The following is a description of a gene set: The hydrolysis of a peptide bond or bonds within a protein as part of the chemical reactions and pathways resulting in the breakdown of a protein by individual cells. Human Gene Set: GOBP_PROTEOLYSIS_INVOLVED_IN_PROTEIN_CATABOLIC_PROCESS species: Homo sapiens, and this is the list of marker genes: CAMLG, TRIM31, UBAP1, HSP90AB1, UBQLNL, ANKRD9, TRIM2, DVL1, TBL1XR1, TAF9 (TATA-box binding protein associated factor 9), DAB2, UBE3D, KLHL2, HSPA1A (heat shock protein family A (Hsp70) member 1A), PSMD3, GBA1, CTSH, SOCS4, PTPN23, FBXL18 (NCBI Gene Id 80028), TRIM9, VPS25, RPS27A, TMTC3, CEBPA, AURKA, FAF2, TMEM129, DNAJB2, CUL3, LONP2, MAGEF1, KLHL10, WNT10B, KLHL22, FBXW8, OPHN1, GIPC1, DNAAF4, ADRM1, NHLRC3, IL33, SKP1, PRAMEF17, IFI27, TMEM168 (transmembrane protein 168), SVIP, RHBDF1, RNF125, ARMC5, NEDD4L, EIF3H, CUL4B, RNF20, GLMN (glomulin, FKBP associated protein), RNF213, PRAMEF14, CTSF, SHH, WAC, WWP2, DCAF11, LAPTM5, APOE, USP38, ANAPC16, PSMB11, RNF150, HECW1, CTNNB1, FBXO46, PRAMEF11, UBE2L3, PTK2, SPOP, PSMC2, BIRC2, TF (NCBI Gene Id 7018), EPM2A, PSMB10, LONP1, PCNP, FBXO45, CDC23, RNF11, UHRF1, MIB1, RNF133, FBXL12, AKT1, ZRANB1, PSME3IP1, SOCS5, PMAIP1, KLHL18, PRKCG, RBBP6, PSMB8, HERPUD1, CAPN2, ANAPC5, ANKZF1, MAN1C1, PRAMEF12, VPS36 (vacuolar protein sorting 36 homolog), ZNRF4 (NCBI Gene Id 148066), KBTBD12, FAU, RCHY1, TMEM259, PRKACA, MVB12B, RPL11, TTC36, RNF123, RNF13, PDCD6IP, UBQLN3, ATXN3L, DMAC2, DET1 (DET1 partner of COP1 E3 ubiquitin ligase), PDCL3, GSK3A, DERL1, KLHL3, RNF185, FBXL3, RNF128, RNF40, ERLEC1, PTEN, PSMA2, GZMB (granzyme B), PSMA3, TRAF7, DAB2IP, ANAPC10, RNF139, BAG2, PHF20L1, TRIM13, VPS28, SUMO2, CHMP4A, MAP1A, PEX12, CTSK, UBL4A, CUL7, RNF187, CALR3, SNF8, UBL7, TRIP4, RHBDD2, PPP2CB, USP17L6P, ANAPC11, IVNS1ABP, VPS37C, FBXO22, PSMD14, NEURL3, ERCC8, ARRDC1, NEMF, UBXN8, SMARCC1 (NCBI Gene Id 6599), JKAMP, SUFU (NCBI Gene Id 51684), SAYSD1, ASB2, DTX4, XPO1 (exportin 1), ZFAND2A, GCLC, UBE2H, RPL23, CBLC, MAEA, UBA52, TRIB2, KLHL20, PELI1, ASB1, PSME1, HAMP, UBA1, GZMA, PSME3, KLHDC2, GID4, ANAPC15, NKD2, CACUL1, AXIN1, BRINP1, RSPRY1 (ring finger and SPRY domain containing 1), PRAMEF5, PSMB3, DCAF1, APPBP2, PARK7, CHMP4BP1, KLHL7, UBE3A, RHBDD1, FBXO31, RNF41, PSMD9, MIDN, RNF25, IKBKG, USP17L24, RAD23B, RNF19B, TRIM58 (tripartite motif containing 58), STAM (signal transducing adaptor molecule), UBE2B, WDR91, VPS4A, CDK2, PSMB4, PLK1, CSNK1A1, RNF26, CPA1, UBE2S, UBE2C, LAMP3, PSMA7, TOR1A, SKP2, CLOCK, KLHDC10, HSP90B1, UBE4A, KCTD17, HERC5, XBP1 (NCBI Gene Id 7494), ECRG4, DNAJC3, PRAMEF25, PSMB5, ZER1, AGAP3, UBE2L5, ALAD, UBE4B, UBE2J2, MTOR, BAP1, HECW2, FBXW7, EGF, FBXO11, RMND5A, FBXL14, KCTD5, RNF8, ZNF598 (zinc finger protein 598, E3 ubiquitin ligase), PSME2, NEDD8, CLPX, ZNRF1, TNFAIP1, KLHL30, DDI2, PABIR1, SOCS6, UBE2N, MALT1 (MALT1 paracaspase), TNFAIP3, WFS1, GSK3B, KLHL41, MIR128-1, CCAR2, PSMF1, CTSL, CHMP2B, AMBRA1, ATP5IF1, FBXO3, PPP2R5C, CHMP3 (charged multivesicular body protein 3), FBXL19, UFSP2, PRAMEF19, ENC1, VHL, AMN1, UBR4 (NCBI Gene Id 57525), HERC6, AXIN2, PSMD10, TRIM26, CANX (calnexin), RHOBTB3 (NCBI Gene Id 22836), KLHL23, NPLOC4, PITHD1, KLHL28, IRGQ, OS9, ATF6, TAF1, LIAT1, RNF148 (NCBI Gene Id 378925), SEM1, CCAR1, PRKN, FBXO4, RNF34 (ring finger protein 34), GET4, NR1D1, CHMP1A, CDC27, RNF130, RNF103 (ring finger protein 103), NDFIP1, CTSB, LATS1 (large tumor suppressor kinase 1), UCHL1, TRIB1, CTSC, PINK1, TRAF4, UBE2W, RNF19A, L3MBTL3, PRAMEF7, UBXN2A (NCBI Gene Id 165324), CDC34, RNF43, DDRGK1, FBXL2, RNF170, SIRT1, KLHL17, KLHL8, CALR, RNF114, EDEM3, STT3B, TMF1, SPSB3, FAM8A1, FBXL5, HERC4, LRRK2, CCDC47, OMA1, NDFIP2, CASP8, RPGR, FBXL15, CBFA2T3, RNF180, AKIRIN2, PSMC4, PABPN1L, SGTA, UBE2Z, DNAJB9, TTC3 (NCBI Gene Id 7267), RNF4, SELENOS, CSNK2A2, PSMC5, KCTD10, DERL2, SOCS2, APC, UBE2I, RACK1, MAN1A2, MTM1 (myotubularin 1), CSNK2A1, SIRT6, SMURF2, COPS3, SUMO1, PEX10, AFG3L2, WWTR1, KLHL1, PSMC1, ANAPC1, DNAJB12, TMX1, UCHL5, PRAMEF15, PJA2, RNF10, UBXN4, PPP1R11, KLHL15, RNF121, MAN1B1, LONRF2, EFNA1, UBE2J1, TRIM32, FOXRED2, KLHL42, HUWE1, PRAMEF10, RNF215, USP14, TBL1X, UBE2D1, KLHL24, CDKN2A, CLU, ZYG11B, SH3RF1, AQP11, IPP, ZNRF3, PSMD8, KBTBD2, SIAH3, OGT, KLHL6, UBXN1, RNF126, MTA1, UBA6, BBS7, SHARPIN, F8A2, GABARAPL2, CDC20B, FBXL17, FEM1B, RNF217, TBX21, UBE3C, ECPAS, RPS7, FBXO44, FBXL7, RNF167, UBAP1L, EDEM2 (ER degradation enhancing alpha-mannosidase like protein 2), PSMD4 (proteasome 26S subunit ubiquitin receptor, non-ATPase 4), LRRC75A, ARAF, UBXN2B, RAD23A, RNF6, UBXN6, CHMP7, NFE2L2, SEC61B, AGBL4, UBE3B, CLPP, AUP1, DTL, IFT80, MYLIP, AREL1, TRPC4AP, UBR7, CUL9, HDAC6, UBQLN1, DCST1, CSNK2B, UBE2K, NHLRC1, PANO1, FBXO38, KEAP1, UBE2D4, TRIM72, WDR26, RNF145, KLHDC3, USP26, VPS37D, KLHL35 (NCBI Gene Id 283212), CSNK1E, RNF166, PLK3, FBXL6, GAN, UBC, PRAMEF27 (PRAME family member 27), PSMD2, WDR77, ITCH, KAT5, UBE2A, UBAC2, UBE2E1 (NCBI Gene Id 94682), PRAMEF4, UBQLN2, CCDC22, TOM1L1, CHMP4C, RPL5, TREM2, RNF168, PSMA1 (proteasome 20S subunit alpha 1), RNF144B, STYX, KLF1, SIAH1 (siah E3 ubiquitin protein ligase 1), EPG5, FAP, KCNE2, USP33 (ubiquitin specific peptidase 33), OTUD7B, LNX1, TRIM71, CHMP4B, ASB11, WDR81, CHMP2A, COMMD1, SYVN1, SMURF1, FBXW5, UBR2, RNF144A, KLHL40, DDI1, RNF186, GABARAP, HECTD1, SIRT2, TMUB1, BMAL1, OTUD7A, UBQLN4, EDEM1, TP53INP2, PSEN1, FEM1A, RLIM, FBXO48, NSFL1C, UCHL3, CTSZ, RNF111, PCBP2, FBXO10, ANAPC2, CHFR, AGTPBP1, UFL1 (UFM1 specific ligase 1), KCTD6, ERLIN2, CLGN, NUDT15, ARHGAP5-AS1, ZFAND2B, RNF149, ZNF418, PSMC3 (NCBI Gene Id 96121), KLHL11, NUB1, DTX3L, HACE1, KLHDC1, RNF5, LGMN, PSMB7, CHMP1B, PCYOX1, FBXO17, SEL1L2, TMEM67, CRBN, FBXW11, CUL1, EPHA4, DDB1, FAF1, UBE2G2, ADAMTS7, HFE, KLHL21, RNF122, SPSB1, ANAPC7, RC3H2, ISG15, FBXO6, ECSCR, CSNK1D, SMAD7, KCTD2, SPSB4, USP19, USP28, HERC2, BAG6, RNF216, RNFT1, MDM2 (MDM2 proto-oncogene), GPX1, SH3RF3, PRAMEF13, PML, RNF7, UBR1, UBE2L6, FBXW4, NOP53, TRIM39, TRIM3, F8A1, UBR5, PTK2B, ADAMTS12, RYBP, PSMD12, RC3H1, RNF14, PSMD13, RNF175 (NCBI Gene Id 285533), F8A3, KBTBD8, CDK5RAP3 (NCBI Gene Id 92989), ARK2N (NCBI Gene Id 147339), RNF115, NTAN1, USP5, YOD1, AFG2B, ERLIN1, PSMB6, NEDD4, ARIH1, UBE2D3, FBXO9, FBXL13, TRIP12, COP1, RMND5B, TRIM25, LTN1, ARRB1, PRAMEF20, SDF2L1, PBK, NCCRP1, SH3RF2, WWP1, VPS37B, HERC3, ZNRF2, RFFL, ANKIB1, KBTBD6, PAQR3, TRIM28, SH3BGRL, IDE (insulin degrading enzyme), QRICH2, TGFB1I1, PRICKLE1, KLHL38, ARIH2, PSMA5, FMR1, FBXO8, MAN1A1, UMOD, FBXL16, SOCS7, KLHL12, CTSV, PRAMEF26, WNT1, PRAMEF6, MVB12A, PRAMEF2, PIAS1, AMFR, UBE2R2 (ubiquitin conjugating enzyme E2 R2), DCAF13, PKD1, NUPR1, OXA1L, RNF146, STUB1 (STIP1 homology and U-box containing protein 1), USP7, SEL1L, MARCHF7, PRAMEF1, RBCK1, TRIM67, TMEM126A, PRAMEF22 (NCBI Gene Id 653606), PSMC6, ASCC2, CDC16, CTSW, PRAMEF18, SPOPL, CCNF (NCBI Gene Id 899), MARCHF6, ANAPC4 (NCBI Gene Id 29945), UBE2G1, STAM2 (NCBI Gene Id 51453), RCN3, SQSTM1, FBXO2 (NCBI Gene Id 4930), DDIT3, DDA1, KCTD13, OSBPL7, BCAP31, PYHIN1, KLHL4, APC2, FBXO7, KCMF1, SENP1, KLHL25, UBB, NFE2L1, FBXL22, FBXO39, UBA7, PCYOX1L, KBTBD7, UBXN11, PSMD1, CHMP5, CNOT4, HGS, BTRC, PSMA4, FBXL20, TMUB2, PRMT6, HM13, KBTBD3, PSMD11, ELOC (NCBI Gene Id 6921), SPSB2 (NCBI Gene Id 84727), KLHL29, PRPF19, PRAMEF9, PSMA8, TRIM38, N4BP1, RBX1, FBXL4, UBE2D2, PSMD7, RNFT2 (NCBI Gene Id 84900), PRAME, USP44, DISC1, GNA12, GID8, HSPA1B, UBXN10, KCTD21, DCAF12, BFAR, VPS4B, KLHL5, NAGLU, ZSWIM8, ELOB (elongin B), YME1L1, PRAMEF33, TOLLIP, USP13, FEM1C, CTSS, MAPK9, DESI1, TRIM21, CDC20, KIF14, DNAJC10, ASB9, CCIN, TRIB3, TSG101, PLAA, FBXO27, CUL4A, CAV1, FBXO21, UBE2U, PSMA6, ARRB2, UBXN7, ANAPC13, ASCC3, CBL, FHIT, CUL2, BAG5, PSMB1, PRAMEF8, HSPBP1, PSMB2, TLK2, UBR3, PSMB9, VCP, ATXN3, HIPK2, AFG1L, CUL5, FZR1, UFD1, ZMPSTE24, CHMP6, ARMC8, HECTD3, ACR, CDC26, DERL3, UBD, FOXF2, CTSO, RFPL1, CAV3, VPS37A, MKRN2, PSMD6, TRIM45, BRSK2, USP25, TOPORS, ATE1, USP9X, HSPA5, SIAH2, PSME4